Given this list of marker genes RFX4, ATP8A1, SLFN13, LRRC59, XPO7, FHIP2A, ANKRD34A, DPP10, ACBD3, ZNF251, PAK2, IL33, CCDC178, PLEKHM3, CLSTN2, SERTM1 (NCBI Gene Id 400120), ERCC6L, RAD21, ITGAV, RBM14-RBM4 (NCBI Gene Id 100526737), FAM199X, ARL6IP6, PPM1E, LY9, CALD1, RPTN, LPGAT1, ANO2, TFAP2A, TMEM33, PTPN4, NIPAL1, CNKSR2, FRMD6, EGR2, CSNK2A1, ZHX3, PTCH1, NXN, BCAP29, RAB28, RTKN2, COBLL1, CIMIP2C, ZBTB33, ZBTB34, ZNF827, C21orf91, MAGEE2, CIMAP2, TBC1D14, EPB41L3, COA5, EML4, PEX13, CD55, VWC2, ATL3, EPC2, TRPC1, AKTIP, ZNF367, PPIL4 (peptidylprolyl isomerase like 4), SMYD2, TRDN (triadin), HNRNPDL, EMC8, GRIA3, KBTBD3, MARCHF6, ELAVL3, MRPL47, NEIL2, RIMS2, KCNA5 (NCBI Gene Id 3741), SIPA1L2, ELOC, ARGLU1, USF3, ITPRIPL2, SNX11, B3GALT2, VPS4B, HOXC4, KIF5B (kinesin family member 5B), ENPP4, CLXN, AZIN1, CADM1, IDI1, CALCR, MAP3K2, CCDC14, NIPA1, CNTN3, GTF2A1, TOX4, ORMDL1, here is a description of the gene set: species: Homo sapiens Human Gene Set: MIR12113 Genes predicted to be targets of miRBase v22 microRNA hsa-miR-12113 in miRDB v6.0 with MirTarget v4 prediction scores > 80 (high confidence targets). from publication Chen Y, Wang X (PMID 31504780)